The following is a description of a gene set: Chylomicron clearance species: Mus musculus Mouse Gene Set: REACTOME_CHYLOMICRON_CLEARANCE, and this is the list of marker genes: Apob, Apoe, Lipc, Ldlrap1, Ldlr